The following is a description of a gene set: studied in species Homo sapiens Human Gene Set: HP_DUODENAL_ATRESIA Duodenal atresia A developmental defect resulting in complete obliteration of the duodenal lumen, that is, an abnormal closure of the duodenum., and this is the list of marker genes: FGF8, FANCI, SUFU, SALL1, RTTN, BUB1, MYCN, FBN2, BUB1B (NCBI Gene Id 701), CEP57, CHD7, DYRK1A, FLI1, STAG2, TRIP13, ZIC2, BUB3, TGIF1, NODAL, GLI2, WBP11, CDON, CAMK2A, KDM3B (lysine demethylase 3B), CFAP45, RFX6, CRIPTO, PTCH1, SHH (NCBI Gene Id 6469), FOXF1, DISP1, CENPF, ZIC3, TTC7A, PIGN, FANCB, SIX3, PORCN, FGFR1, RFWD3, FOXH1, FANCF, RERE (NCBI Gene Id 9642), GAS1, DLL1